Given this list of marker genes LHX3, MFF, SIX6, FKRP, POMGNT1, GPKOW, NODAL, MAN2C1, FGFR1, HEXB, OFD1, POMK, STX1A, KIF7, KIAA0753, ANOS1, TOPORS, SCP2 (NCBI Gene Id 6342), PDE6D, NF2, PTCH1, GLI2, CDON, FGF17, SMO, EXOC2, TERT, VPS16, SOX10, PROK2, FTL, SMARCB1, DNAJC30, GTF2IRD1, SEMA3A, NDE1, TRAF7, GSX2, MTRFR, TBL2, TMEM216, RFC2, STIL, IL17RD, DUSP6, CCDC141, STAG2, SMARCE1, FAM149B1, VPS37D, HS6ST1, CP, SHH, PDGFB, NDNF, GTF2IRD2, TREM2, BAP1, MAGEL2, FEZF1 (NCBI Gene Id 392779), GLI3 (NCBI Gene Id 2737), ELN, DCC, NCF1, COX10, TMEM231, FGF8, NDP, CTNNB1, JAM2, CPLANE1, SPRY4, TWNK, MED17, POMT1, GAS1, DLL1, WDR11, SIX3, TUBB3, LIMK1, SOX2 (SRY-box transcription factor 2), PLCH1, SIM1, GMPPB, HESX1, CLN8, FKBP6, DISP1, PIK3C2A, CMPK2, TUBA1A, CRIPTO, ZIC2, SPG11, PROKR2, TMEM270, TACR3 (tachykinin receptor 3), CHD7, BUD23, RANBP2, AKT1 (NCBI Gene Id 207), SLC2A1 (NCBI Gene Id 6513), POLG, MYORG, PTCD3, SETD5, COASY, BRAF, GTF2I, TGIF1, TIAM1, SMC1A, TCTN3, FLRT3, PIK3CA, CDH2, METTL27, BAZ1B, EXOC7, EIF4H, LEPR, GTPBP3, POMT2, TUBB2B, CLIP2 (CAP-Gly domain containing linker protein 2), TRH, FOXH1, GFAP, SUFU, here is a description of the gene set: An abnormality of the Diencephalon, which together with the cerebrum (telencephalon) makes up the forebrain. species: Homo sapiens Abnormal diencephalon morphology Human Gene Set: HP_ABNORMAL_DIENCEPHALON_MORPHOLOGY